Given this list of marker genes COL10A1, RSPRY1 (NCBI Gene Id 89970), CFAP410, COL2A1, DNAJC21 (NCBI Gene Id 134218), TRPV4, KIAA0586, CSPP1, RPL13, SRP54, SBDS, here is a description of the gene set: Irregularity of the normally smooth surface of one or more metaphyses of a bone of the leg. Human Gene Set: HP_LOWER_LIMB_METAPHYSEAL_IRREGULARITY studied in species Homo sapiens Lower-limb metaphyseal irregularity